The following is a description of a gene set: Human Gene Set: GOBP_CELLULAR_RESPONSE_TO_ABIOTIC_STIMULUS species: Homo sapiens Any process that results in a change in state or activity of a cell (in terms of movement, secretion, enzyme production, gene expression, etc.) as a result of an abiotic (non-living) stimulus., and this is the list of marker genes: TLR8, SPIDR, ARHGEF2, TNFRSF8, RGR, RAB11FIP5, MME, BLM, TLK2, CHEK1 (NCBI Gene Id 1111), CASP1, RUVBL2, IRF1 (interferon regulatory factor 1), AURKB, NPM1, KCNJ2, PTPN11 (protein tyrosine phosphatase non-receptor type 11), INTS7, NOC2L, GUCY2D, ELK1, CDKN1A, RGS9, SFRP2, DDB1, BMP6, ZFP36L1, RPL26, NIPBL, MAP2K4, FBXO4, NFKB1, CLOCK, CUL4B, RBX1, GPR65, OPN1MW, MYC, LIG4, TMEM87A, ADSS2, GPR68, IFI16, YAP1, ECT2, ATF4, PCP2, BDKRB2, EIF2AK4, CHEK2 (checkpoint kinase 2), PRKCD, TRPV3, OPN1LW, HYAL2, TLR5, MDM2, PRAP1, GPR88, BMF, PARTICL, AIPL1, EPO, GRM1, XPC, SCNN1B, WRN, RHBDD1, PKD2L1, BARD1, SDE2, ASIC1, CRADD, BAG3, SLC24A4, EEF1D (NCBI Gene Id 87167), COPS9, GCLC, NFATC4, GAB1, SMPD1, STK39, KDM1A, F11R, GPR52, LRRC8E, TLR4, RP1, CYBA, ERCC1, N4BP1, SIPA1, BAD, TP53BP1, OPN3 (opsin 3), RAD51, AQP1, MAPK3, CASP2, ST20, NPPA, POLD1, CLCN2, PBK, BRCA2, POLD3, SCN7A, TP53INP1, CRB1, LCN2, ATP1A1, NET1, RAD9A, NEDD4, TANK, CERS1, MLST8, ATR, RHO, USP28, SLC9A1, CAPN3, STK11, AQP2, WNK3, EIF2S1, AKR1B1, IL1B, CALR, XRCC5, DDB2, SLC38A2, SLC2A1 (NCBI Gene Id 6513), TRPV4, MTOR, LRRC8D, SNAI2, GTF2H5, MYD88, EP300, PIEZO1, WNT11, HVCN1, PKD1L3 (polycystin 1 like 3, transient receptor potential channel interacting), ITGB3, PDE2A, CD40, ASCL1 (NCBI Gene Id 429), GOT1, CHP1, CAB39, GATA3, ITGB6, BRCC3, PIERCE1, ATM, RELB, CAMKMT, ATP1A2, TLR3, PLEC, PALM, TRPM1, MIR21, CRY2, HYAL3, SLC12A6, TNKS1BP1 (NCBI Gene Id 85456), GADD45A, ZFAND1, ZBTB1, WNK1, NMT2, TMEM161A, OPN5, BCL2L1, AQP5, NINJ1, PIEZO2, VPS13A, TMEM150C, FBP1, DHX36, CUL4A (cullin 4A), MAPK11, COL1A1, NLK, POLK, RHNO1, ABCB1, LTBR, GRB2, CASP8AP2, TREX1, KDM4D, RPTOR, GNA11, SAG, GRK1, SLC2A4, CRYAB, MC1R, RHOB, NFAT5, SCNN1A, CASP8, MAP3K1, MAG, TRIAP1, KCNK3, MAP3K2, CASP3, RAB11B, BRCA1, CCND2, RAD51AP1, PTEN, OXSR1, METTL3, EGR1, CASP9, MYLK, MAPK13, TIMP1, PYCARD, PARP1, MMP9, RAD9B, MMP2, GPLD1, XPA, OPN4, TMEM109, PTGS2, MAPK8, ACTR5, MMP3, CASP5, BABAM2, NLRP1, HSF1, HYAL1, TGFB1, FGF2, FADD, RCSD1 (NCBI Gene Id 92241), ZMPSTE24, PIK3R1, SCNN1D, CNN2, HRAS, TNFSF14, XRCC6, NLRP3, CREBBP, FXYD2, GNAT1, INSRR, SERPINB6, FAS, EI24, AKT2, OPN1SW, BCL10, NMT1, HPCA, GUCY2F, BAX, PTGER4, SLC4A11, H2AC25, KCNK18, HDAC3, SCN2A, SIRT1, PIK3CA, OPN1MW2 (opsin 1, medium wave sensitive 2), MTCH2, MMP1, FIGNL1, ADSS1, REST, SOX9, LRRC8C, RAD1, NSMCE3, GPR4, MAP3K14, HUS1, NUCKS1, TNFRSF10B, PPID, OPN1MW3, DDX3X, KCNK4, LETM1, SCX, MFAP4, MICU1 (mitochondrial calcium uptake 1), AVPR1A, YBX3, KCNK9, ASIC2, NSMF, ITGA2, IL13, GNB5, SLC24A2, MAPK14, ANKRD1, SWI5, MCOLN1, SFRP1, TSPO, BAK1, TNF, PKD2, ERCC4, INO80, PTPRK, CLN3, GRK4, EFHD1, TNFRSF10A, RRH, YY1, FBXW7, ERRFI1, TEK, MAP3K20, USP15, TIFAB, BNIP3, TRPV1 (NCBI Gene Id 7442), NEUROD2, POLH, TP53, TNFRSF1A, TSPYL5, SCNN1G, CRIP1, GRK7, TAF1 (NCBI Gene Id 6872, TATA-box binding protein associated factor 1), CRY1, SLC25A23, HABP4, POLA1, TLR7, BBC3, KCNK1, PECAM1, PCNA, DAG1